Given this list of marker genes SPAG5, MCPH1, SPRY1, NSFL1C, MAD2L1, NDE1, LLGL2, NDEL1, MAPRE1, ZW10, SPDL1, DYNLT1, DCTN1 (dynactin subunit 1), GJA1, GPSM1, MAP4, BCCIP, HDAC3, MISP, MOS, ENKD1 (NCBI Gene Id 84080), PLK1, CLASP1, CDK5RAP2, SKA3, KAT5, ITGB1, INPPL1, PKHD1 (NCBI Gene Id 5314), HTT, GPSM2, KIF25, CENPA, FBXW11, CCDC66, SPRY2, SKA2, NDC80, LLGL1, PAFAH1B1, NUMA1, SKA1, SAPCD2, ANKFN1, FGF10, UBXN2B, PAX6, here is a description of the gene set: Human Gene Set: GOBP_ESTABLISHMENT_OF_SPINDLE_ORIENTATION Any process that set the alignment of spindle relative to other cellular structures. studied in species Homo sapiens